Given this list of marker genes Scn4b, Cxadr, Cacna1c, Scn10a, Ank2, Scn5a, Gja5, Cacnb2, Trpm4, Ryr2, here is a description of the gene set: studied in species Mus musculus Any process that mediates the transfer of information from an AV node cardiac muscle cell to a bundle of His cardiomyocyte. Mouse Gene Set: GOBP_AV_NODE_CELL_TO_BUNDLE_OF_HIS_CELL_SIGNALING